Given this list of marker genes GBX2, MSX1, NES, DCX, ZIC1, TUBB3, SOX1, here is a description of the gene set: Genes up-regulated in EpiSC cells (mouse epiblast embryonic stem cells) after treatment with the ALK inhibitor SB-431542. studied in species Mus musculus Human Gene Set: TESAR_ALK_TARGETS_EPISC_3D_UP The application of human embryonic stem (ES) cells in medicine and biology has an inherent reliance on understanding the starting cell population. Human ES cells differ from mouse ES cells and the specific embryonic origin of both cell types is unclear. Previous work suggested that mouse ES cells could only be obtained from the embryo before implantation in the uterus. Here we show that cell lines can be derived from the epiblast, a tissue of the post-implantation embryo that generates the embryo proper. These cells, which we refer to as EpiSCs (post-implantation epiblast-derived stem cells), express transcription factors known to regulate pluripotency, maintain their genomic integrity, and robustly differentiate into the major somatic cell types as well as primordial germ cells. The EpiSC lines are distinct from mouse ES cells in their epigenetic state and the signals controlling their differentiation. Furthermore, EpiSC and human ES cells share patterns of gene expression and signalling responses that normally function in the epiblast. These results show that epiblast cells can be maintained as stable cell lines and interrogated to understand how pluripotent cells generate distinct fates during early development. from publication Tesar PJ, Chenoweth JG, Brook FA, Davies TJ, Evans EP, Mack DL, Gardner RL, McKay RD (PMID 17597760)